Given this list of marker genes Map2k4, Rack1, Stk25, Pdcd10, Pink1, Trap1, Park7, here is a description of the gene set: Mouse Gene Set: GOBP_INTRINSIC_APOPTOTIC_SIGNALING_PATHWAY_IN_RESPONSE_TO_HYDROGEN_PEROXIDE The series of molecular signals in which an intracellular signal is conveyed to trigger the apoptotic death of a cell. The pathway is induced in response to hydrogen peroxide (H2O2). species: Mus musculus